Given this list of marker genes Aire, Havcr2, H2-M3, Foxp3, C3ar1, here is a description of the gene set: studied in species Mus musculus Mouse Gene Set: GOBP_TOLERANCE_INDUCTION_DEPENDENT_UPON_IMMUNE_RESPONSE Tolerance induction dependent upon an immune response, typically a response by a mature T or B cell in the periphery resulting tolerance towards an antigen via induction of anergy, cellular deletion, or regulatory T cell activation.